The following is a description of a gene set: Human Gene Set: HP_ADRENOCORTICOTROPIC_HORMONE_EXCESS Adrenocorticotropic hormone excess species: Homo sapiens Overproduction of adrenocorticotropic hormone (ACTH), which generally leads secondarily to overproduction of cortisol by the adrenal cortex., and this is the list of marker genes: HSD3B2, ABCD1, CYP11A1, CYP17A1, MCM4